The following is a description of a gene set: A developmental defect resulting in the presence of fewer than the normal number of toes. Human Gene Set: HP_FOOT_OLIGODACTYLY species: Homo sapiens Foot oligodactyly, and this is the list of marker genes: SF3B4, APC, DLX5, DLL4, WNT10B, GLI3, SMOC1, ERI1, LRP4, WNT7A, PORCN